The following is a description of a gene set: from publication Dirmeier U, Hoffmann R, Kilger E, Schultheiss U, Briseño C, Gires O, Kieser A, Eick D, Sugden B, Hammerschmidt W (PMID 15674340) Human Gene Set: DIRMEIER_LMP1_RESPONSE_LATE_DN studied in species Homo sapiens Cluster 4: genes down-regulated in B2264-19/3 cells (primary B lymphocytes) within 60-180 min after activation of LMP1 (an oncogene encoded by Epstein-Barr virus, EBV). Latent membrane protein 1 (LMP1), an oncoprotein encoded by Epstein-Barr virus (EBV), is an integral membrane protein, which acts like a constitutively active receptor. LMP1 is critical for some facet of EBV's induction and maintenance of proliferation of infected B cells. It, in part, mimics signaling by the CD40 receptor and has been implicated in regulating proliferation, survival, or both properties of EBV-infected cells. We established a conditional LMP1 allele in the context of the intact EBV genome to define the immediate-early cellular target genes regulated by LMP1 in order to assess its contributions to infected human B cells. The functional analysis of this conditional system indicated that LMP1 specifically induces mitogenic B-cell activation through c-myc and Jun/AP1 family members and confirms its direct role in upregulating expression of multiple genes with opposing activities involved in cell survival. LMP1's signals were found to be essential for the G1/S transition in human B cells; cells lacking LMP1's signals are cell cycle arrested and survive quiescently. LMP1's activities are therefore not required to maintain survival in nonproliferating cells. LMP1 does induce both pro- and antiapoptotic genes whose balance seems to permit survival during LMP1's induction and maintenance of proliferation., and this is the list of marker genes: RPLP0, RPS19, ARHGDIB, E2F2, UBC, DENND2B, MAP4K1, RPS5, LSM2, RPS11, ARF5, ASAH1, TXNIP, COL11A2, CD27, CHI3L2, IFITM1, PSAP, RPL29, ISG15, TAF10, PSMB9, FAU, APOC4, HPCAL1, WAS, BTG1, GAPDH, HLA-DMA, COX8A